Given this list of marker genes SHARPIN, LYN, HLA-DRB1, CXCR4, BTNL2, PSMB8, here is a description of the gene set: Parotitis Human Gene Set: HP_PAROTITIS Inflammation of the parotid gland. studied in species Homo sapiens